The following is a description of a gene set: studied in species Homo sapiens Any process that stops, prevents, or reduces the frequency, rate or extent of axon extension involved in axon guidance. Human Gene Set: GOBP_NEGATIVE_REGULATION_OF_AXON_EXTENSION_INVOLVED_IN_AXON_GUIDANCE, and this is the list of marker genes: PLXNA3, HDAC6, SEMA5A, WNT3, NRP1, SLIT1, WNT5A, WNT3A (Wnt family member 3A), SEMA3F, RYK